The following is a description of a gene set: Genes predicted to be targets of miRBase v22 microRNA mmu_miR_122_5p in miRDB v6.0 with MirTarget v4 prediction scores > 80 (high confidence targets). from publication Chen Y, Wang X (PMID 31504780) species: Mus musculus Mouse Gene Set: MIR_122_5P, and this is the list of marker genes: Aldoa, Gys1, Dao, Fundc2 (NCBI Gene Id 67391), Shprh, Golph3l, Vamp3, Brpf1, Ankrd13c, Rabl6, Car10, 9330182O14Rik, Cyp4f37, Slc25a34, Samd5, Fli1, Alox12, Npepps, Igsf5, Tnrc6a, Adgrb2, Slc4a1, Rbm47, Pxmp4, Ces2g, Gpr141b, Flnb, Cpeb1, P4ha1, Gnpda2, Slc2a3, Ccng1, H2-T24, Lamc1, Phaf1, Cux1, Pkm, Pex26, Ror1 (receptor tyrosine kinase-like orphan receptor 1), Spcs2, Hnrnpu, Akap10, Arfip2, Rfpl4, Fuca2, Slc41a1, Dglucy, Spata7, Prdm15, Zfp668, Ddx60, Dicer1, Ocln, Phf19, Tbr1, Mllt1, Nol4l (NCBI Gene Id 98957), Grhl2, Atp1b1, Maf1, Slc52a2, Zfp809, Slc7a1, Ppip5k1, Micu3, Grem2, Smarcd1, Adss2, Snx17, Nmur2